The following is a description of a gene set: Genes in the expression cluster 'ST-HSC Shared': up-regulated in short term hematopoietic stem cells (ST-HSC) from adult bone marrow and fetal liver. from publication Ivanova NB, Dimos JT, Schaniel C, Hackney JA, Moore KA, Lemischka IR (PMID 12228721) Mechanisms regulating self-renewal and cell fate decisions in mammalian stem cells are poorly understood. We determined global gene expression profiles for mouse and human hematopoietic stem cells and other stages of the hematopoietic hierarchy. Murine and human hematopoietic stem cells share a number of expressed gene products, which define key conserved regulatory pathways in this developmental system. Moreover, in the mouse, a portion of the genetic program of hematopoietic stem cells is shared with embryonic and neural stem cells. This overlapping set of gene products represents a molecular signature of stem cells. species: Mus musculus Human Gene Set: IVANOVA_HEMATOPOIESIS_STEM_CELL_SHORT_TERM, and this is the list of marker genes: SENP6, PRKCA, PDE1A, MPHOSPH9, UBXN10, PRRG1, HIRIP3, BPNT2 (NCBI Gene Id 54928), APC, KIF16B, SLC5A12, RDM1, MATR3, BPTF, ERBIN, PKP1, DNTT, PMS2 (PMS1 homolog 2, mismatch repair system component), NCOA6 (nuclear receptor coactivator 6), BCLAF1, C9orf50, TSPAN1